The following is a description of a gene set: Genes predicted to be targets of miRBase v22 microRNA mmu_miR_195a_3p in miRDB v6.0 with MirTarget v4 prediction scores > 80 (high confidence targets). from publication Chen Y, Wang X (PMID 31504780) species: Mus musculus Mouse Gene Set: MIR_195A_3P, and this is the list of marker genes: Trps1, Ctsl (NCBI Gene Id 320361), Cbln2, 4921524J17Rik, Tmc3, Rora (RAR-related orphan receptor alpha), Pafah1b1, Cadps2, Lrrc8d, Rap1a, Wbp4, Lrig1, Rnf44, Csmd1, Steap2, Btbd8, Nedd9, Fgf14, Acer3, Hand2, Dip2b, Pias2, Ttc39b, Kdm7a, C1qtnf7, Zc3hav1l, Pclo, Kctd15, Cadm2, Fsd1l, Kcnmb2, Rbfox1, Zfp236, Pcgf3, Ube2i, Macir, Gabrg1, Sdc2, ENSMUSG00000121861, Ankrd66, Spink11, Llgl1, Ranbp3, Arfgef1, Terb2, Tent4a, Tafa2, Negr1, Cntn4, Cnr1, Id1, Clspn (claspin), Sin3b, Zfp746, Mme, Nabp1, Kif5b, Adam9, Ano3, Klf2, Cltc, Pld5, Bmi1, Lin54, Zdhhc17, Gabra3, Gpalpp1, Mier3, Chic1, Hmcn1, Cntn3, Lhx9, AU041133, Tubb5, Tfap2c (transcription factor AP-2, gamma), Cul3, Rock1, Eps8, Chac2, Fam181a, Zfp945, Cdk17, Odr4, Rai14, Erich4, Cilk1, Prkg1, Rp2, Gykl1, Vkorc1l1, Gadd45b, Bbs5, Sspn, Mbp, Rhox5, Rad51d, Mob1b, Mkks, Ccn2, Idi1, Adcyap1, Hif1a, Phip, Spock3, Galnt1, Tshz1, Dnal1, Osbpl8, Pax9, Rab1a, Hrnr, Aebp2, Ube2b, Secisbp2l, Mbd5, Pter, Bri3bp, Sod2, Tlcd4, Ptbp3, Ipo8, Tcerg1l, Fndc1 (NCBI Gene Id 68807), Pdlim5, Lrrcc1, Defb48, Zfp729b, Zfx, Arrdc3, Zup1, Cebpd, Nus1, Cul2, Mfsd14b, Ssb, Tmem161b, Dsn1, Ccdc141, Hnmt, Iyd, Mtf2